Given this list of marker genes MAPK1, MAPK3, POMC, EGFR, USP8, here is a description of the gene set: Mutation-activated USP8 to EGFR-ERK-ACTH signaling pathway. Pathway ID: N00319. Pathway type: Variant. Pathway class: nt06310 CRH-ACTH-cortisol signaling. Pathway Definition from KEGG: USP8* -> EGFR -> ERK1/2 -> ACTH species: Homo sapiens Human Gene Set: KEGG_MEDICUS_VARIANT_MUTATION_ACTIVATED_USP8_TO_EGFR_ERK_ACTH_SIGNALING_PATHWAY